Given this list of marker genes Capn3, Hmg20a, Rela, Ctnnb1 (catenin beta 1), Park7, Hmg20b, Fscb, Pias3, Gnl3l, here is a description of the gene set: Any process that stops, prevents, or reduces the frequency, rate or extent of the addition of SUMO groups to a protein. studied in species Mus musculus Mouse Gene Set: GOBP_NEGATIVE_REGULATION_OF_PROTEIN_SUMOYLATION